Given this list of marker genes GRIN3A, SLC6A3 (solute carrier family 6 member 3), DRD2, PTEN, CNTNAP2, BACE1, DVL1, DRD1, GRID2, ADORA2A, DRD3, CHD8, CTNNA2, here is a description of the gene set: The process in which a startle magnitude is reduced when the startling stimulus is preceded by a low-intensity prepulse. studied in species Homo sapiens Human Gene Set: GOBP_PREPULSE_INHIBITION